Given this list of marker genes ITM2C, CRABP2, SERF2, ECE1, SLC39A7, LSR, TOR3A, UBE2W, PXK, VCP, CCN3, NEK6, SEPTIN6, CADM1, SEC61G, CXCR3 (NCBI Gene Id 2833), POLR2L, PPP1R14B, DBNL, CBR3, ACR, DNAJC3 (DnaJ heat shock protein family (Hsp40) member C3), NSMCE1, COQ7, UBXN6, SRM, VDAC2, FBXO15, RPL13A, ACOD1 (aconitate decarboxylase 1), THAP4, DLGAP4, EIF6, TAP1, UQCR10, KCNS1, ATP5F1C (ATP synthase F1 subunit gamma), ANGPTL2, ALDOC, CD2BP2, FUCA1, MOGS, PRKCSH, CDK1, SLC5A1, SLC25A20, GADD45A, PLXNA1, GSTT2, PLIN2, PERP, RAMP1, B3GALT1, DTL, ODC1, RPS18, ACAA1, PPIB, TNNT3, KAT2A, MID1IP1, RNF145, BCHE, HLTF, MPRIP, HINT1, TAP2, RALA, SCIN, RAB7A, GJC1, USP3, CST3, ST3GAL5, LY75, NDUFA7, NDUFS5, RPS26, XCR1, NDUFB11, AP3S1, SOWAHC, RTN4, SDSL, PSAP, RAB11A, VAX2, LARP1, PKIB, HESX1, IL2RB, SCARB1, ERF, FBXW2, IL13, CYC1, NFE2L1, AKR1B15, SLC35E4, RPL28, LY6E, SLC6A6 (solute carrier family 6 member 6), NPNT, TPD52L1, CD6 (NCBI Gene Id 923), SPPL2B, PABPC1, TM4SF5, ERP44, SNX17, NHP2 (NHP2 ribonucleoprotein), NABP1, TWSG1, KITLG, BMP8B, MPEG1, PDIA5, TAPBP, RPL18, LMNA (lamin A/C), MDM2 (NCBI Gene Id 84825), CYSTM1, GNAZ, DCTN3, DPAGT1, ANXA10, RPL37, MRPL54, MRPS7 (NCBI Gene Id 64967), PRDX2, CD81, LPCAT1, SLC11A1, NET1, IRF7, SEZ6, SLC52A2, ATP5F1A, PSMB8, PI4K2A, ST6GALNAC1, BCL2L11, PML, MAN1B1, C1QTNF1, RACK1, INTS5, KCTD10 (potassium channel tetramerization domain containing 10), TPI1, PPP1R12C, VPS37C, STK10, CDC37, PEX5, UMOD, TUBB6, CAPNS1, CORO1B, ARIH2, TNFAIP8, SSU72, EXT2, FNBP1, ESYT1, PAFAH1B3, NUMB, CLASRP, MYB, CRIP1, HIGD2A, DHRS1, AKR1A1, MACROD2, TET1, RENBP, NUCB2 (nucleobindin 2), NPC2, USP17L2, MTARC2, SRRT, AP3D1, ANXA5, HOMER3, MACROH2A1, ERP29, KIFAP3, AP1M1, TBCA, SLC25A10 (NCBI Gene Id 1468), IL13RA2, RNASEK, PRSS8, C1QC, CNN2, BSCL2, MT1E, MYCBP, LAPTM4B, KIF3C, BOLA2, here is a description of the gene set: from publication Edwards AD, Chaussabel D, Tomlinson S, Schulz O, Sher A, Reis e Sousa C (PMID 12816982) species: Homo sapiens Genes down-regulated in comparison of CD4 dendritic cells (DC) versus CD8 DCs. The functional relationships and properties of different sub-types of dendritic cells (DC) remain largely undefined. We used a global gene profiling approach to determine gene expression patterns among murine splenic CD11c high DC subsets in an effort to better characterise these cells. Human Gene Set: GSE339_CD4POS_VS_CD8POS_DC_IN_CULTURE_DN